The following is a description of a gene set: species: Homo sapiens The directed movement of proteins from the endosome to the plasma membrane in transport vesicles. Human Gene Set: GOBP_ENDOSOME_TO_PLASMA_MEMBRANE_PROTEIN_TRANSPORT, and this is the list of marker genes: RAB8A, NSG1, TRARG1, GRIPAP1, SCARB2, AKAP5, VPS35, RAB11A, GRIP1, RAB7A, LRRC7, ATP6AP1, COMMD1, ZDHHC2, SORL1, SCRIB (scribble planar cell polarity protein, NCBI Gene Id 23513), ARHGAP44, GRIP2, VAMP4